Given this list of marker genes FGF8, OTP, POU3F2, WNT4, NOTCH1, BMP2, HES1, INSM1, NKX6-3, ASCL1 (achaete-scute family bHLH transcription factor 1), FGF2, GATA2, NKX2-2, JAG1, WNT11, RFX6, LHX3, BCCIP, ONECUT1, here is a description of the gene set: Human Gene Set: GOBP_NEUROENDOCRINE_CELL_DIFFERENTIATION The process in which a relatively unspecialized cell acquires specialized structural and/or functional features of a neuroendocrine cell. A neuroendocrine cell is a cell that receives input form a neuron which controls the secretion of an endocrine substance. studied in species Homo sapiens